The following is a description of a gene set: species: Mus musculus Mouse Gene Set: REACTOME_S_PHASE S Phase, and this is the list of marker genes: Pole, Dna2, Psmd1, Rad21, Cdk4, Anapc15, Orc1, Orc5, Orc4, Anapc1, Pola1, Mcm5, Cdc6, Akt2, Psmc2, Pds5a, Mcm3, Gins1, Cdk7, Orc3, Rpa2, Ptk6, Rpa1, Lig1, Ccna1, Psmc3, Orc2, Psmb1, Rfc1, Psmd2, Psmb6, Gmnn, Cdkn1b, Anapc5, Psmc5, Akt1, Skp2, Cdc27, Uba52, Cul1, Prim2, Cdca5, Ccnh, Rfc2, Psma3, Rbx1, Cdkn1a, Mcm2, Psmc4, Orc6, Stag2, Psmd6, Cables1, Anapc10, Mcm7, Ccne2, Mcm8, Akt3, Fzr1, Stag1, Smc3 (structural maintenance of chromosomes 3), Psmb7, Rps27a, Psma1, Pole4, Cdk2, Anapc11, Smc1a, Ubb, Ccne1, Cdc25a, Ube2s, Ccna2, Psmc6, Psma4, Anapc2, Uba52rt, Gins2, Pcna, Psmd14, Rfc4, Gins3, Psmd8, Cdt1, Pola2, Psmb2, Psmb5, Anapc4, Prim1, Psmb4, Rfc5, Mnat1, Anapc16, Cks1b (CDC28 protein kinase 1b), Pds5b, Psmd7, Cdc23, Pold2, Cdc25b, Pold1, Esco1, Ube2c, Psmd13, Pole3, Ccnd1, Gins4, Psmd12, Psmd3, Cdc26, Wee1, Rfc3, Pold4, Mcm4, Rb1, Rpa3, Ube2d1, Pole2, Psma6, Fen1, Psmb3, Psma2, Wapl, Psmd11, Adrm1, Cdc16, Esco2, Anapc7, Ube2e1, Psmc1, Psma7, Ubc, Cdkn1c, Mcm6, Psma5, Skp1, Pold3